Given this list of marker genes RRAS, FUT1, PLPP3, CEACAM6, RIN2, MIR92A1, GFUS, MMP12, LEF1, here is a description of the gene set: Human Gene Set: GOBP_ENDOTHELIAL_CELL_MATRIX_ADHESION_VIA_FIBRONECTIN species: Homo sapiens The binding of an endothelial cell to the extracellular matrix via fibronectin.